Given this list of marker genes USP47, DDB1, TERC, CDC5L (NCBI Gene Id 988), CCT6A, MYB, here is a description of the gene set: Binding to a WD40 repeat domain of a protein. The WD40 repeat is a short structural motif of approximately 40 amino acids, often terminating in a tryptophan-aspartic acid (W-D) dipeptide. Several of these repeats are combined to form a type of protein domain called the WD domain. studied in species Homo sapiens Human Gene Set: GOMF_WD40_REPEAT_DOMAIN_BINDING